Given this list of marker genes Ecrg4, Klhl8, Tdpoz2, Aurka, Traf4, Gid4, Klhl4, Ivns1abp, Nop53, Trip4, Gba1, Klhdc10, Ube2d3, E330034G19Rik, Fbxl18, Itch, Cul2, Afg2b, Psmd2, Clu, Araf, Bag5, Klhl3, Pramel32, Gna12, Rnf186, Gsk3b, Pabpn1l, Ube2u, Trim39, Kbtbd2, Pmp22, Anapc13, Rbck1, Psmb3, Gipc1, Ubxn2b (NCBI Gene Id 76194), Chfr, Cop1, Psmb10, Rchy1, Fem1a, Nkd2, Sharpin, Asb9, Fbxl20, Klhl7, Fbxw11, Anapc7, Nemf, Psma7, Csnk1e, Klhl40, Ube2a, Pramel44, Dcaf12 (NCBI Gene Id 99997), Peli1, Pramel43, Clock, Wac, Axin2, Kbtbd8, Epm2a, Anapc5, Oog2, Stub1, Trf, Fbxl7, Trpc4ap, Nhlrc3, Trip12 (NCBI Gene Id 73751), Ubr3, Klhl38, Psmb7, Klhl41, Fbxo3, Trim13, Ufd1 (ubiquitin recognition factor in ER-associated degradation 1), Clec16a, Csnk1d, Kctd5, Sumo1, Pramel28, Rnf126, Klhl42, Ube2srt, Pml, Gclc, Trim45, Pja2, Pabir1, Bag6, Akirin2, Tdpoz8, Fbxl5, Klhl29, Cul1, Psmd1, Spsb1, Tbx21, Psmc5, Fbxo44, Ube2h, Znrf1, Kbtbd6, Fbxl14, Cbfa2t3, Styx, Csnk2b, Psmc1, Klhl12, Kctd13, Naglu, Cdc20b, Klhl23, Psma5, Armc8, Ube3d, Prickle1, Plk2, Ambra1, Pramel21, Ubxn11, Fbxl6, Smurf2 (SMAD specific E3 ubiquitin protein ligase 2), Zyg11b, Pramel11, Fbxw4, Pramel53, Fbxo4, Fem1al, Anapc2, Pramel51, Pramel42, Tdpoz3, Skp1, Derl1, Psmb4, Psmb9, Kat5, Ankrd9, Zswim8, Ube2n, Spsb2, Fbxl3, Pramel19, Fbxl22, Pramel45, Bbs7, Fbxl2, Pramel60, Trib1, Ubr4, Nploc4, Psmc4, Csnk2a2, Klhl6, Spop, Psmb8, Ubxn7, Trib3, Pramel40, Vhl, Fbxl13, Tnfaip1, Socs2, Kcmf1, Hspbp1, Sh3rf3, Dmac2, Keap1, Asb11, Wdr26, Snhg15, Sh3bgrl, Klhl35, Siah2, Ube2g1, Asb2, Phf20l1, Rad23b, Psmd7, Psmc6, Rbx1, Nedd4l, Plaa, Ubr1, Dtx4, Nub1, Fbxw8, Tdpoz5, Sh3rf1, Mapk8, Ascc2, Klhl11, Psmd8, Pramel13, Rnf216, Klhl24, Fem1b, Trim9, Ubxn1, Huwe1, Marchf6 (membrane associated ring-CH-type finger 6), Psmd10, Ddit3, Ltn1, Zfp418, Fbxw7, Psen1, Fzr1, Fbxo17, Fbxo39, Psmd4, Pramel7, Ccnf, Klhl20, Pramel20, Arih2, Asb1, Fbxw5, Mta1, Anapc4 (NCBI Gene Id 67924), Klhl22, Hectd3, Dcaf11, Gid8, Ube2c, Shh, Ppp2cb, Znrf4, Foxf2, Klhl21, Kbtbd7, Ipp, Psmd14, Tdpoz1, Ube2k, Btrc, Kctd2, Cdc34b, Sirt6, Fbxo9, Pramel46, Usp38, Arrb2, Dab2, Dtl, Psmb11, Pramel37, Gsk3a, Wwp1, Nfe2l2, Pramel18, Pramel36, Rack1, Kctd17, Usp5, Trim72, Cdc27, Pramel35 (PRAME like 35), Plk1 (NCBI Gene Id 18817), Caml, Apc, Spsb3, Ubr5, Rmnd5a, Pcbp2, Psmb5, Klhl15, Psmb2, Pbk, Ercc8, Cul5, Pramel47, Siah1b, Ccin, Tlk2, N4bp1, Pramel48, Cul3, Ube3a, Anapc1, Fbxl19, Rffl, Ubr2 (ubiquitin protein ligase E3 component n-recognin 2), Senp1, Dcaf13, Otud5, Fbxo6, Cdc26, Cul4a, Rbx1-ps, Smurf1 (SMAD specific E3 ubiquitin protein ligase 1), Bmal1, Akt1, Psmf1, Psma8, Nhlrc1, Pramel23, Uchl5, Pramel14, Fbxl4, Herc2, Pramel17, Usp7, Gabarap, Eif3h, Skp2, Wnt10b, Psmc2, Cd2ap, Pramel22, Pramel12, Pias1, Syvn1, Kctd10, Anapc15-ps, Ubxn2a, Ube2d1, Psma2, Taf9, Dvl1, Commd1, Socs4, Klhl28 (NCBI Gene Id 76837), Maea, Pramel25, Bfar, Klhl18, Ascc3, Amn1, Pcnp, Pramel55, Dda1, Psmd6, Rybp-ps, Klhl30, Oog3, Rmnd5b, Tdpoz4, Zfand2a, Ctnnb1, Pramel31, Klhdc1, Styx-ps, Hamp, Trim3, Hspa1a, Pramel41, Rnf180, Psma6, Det1, Smarcc1, Ubqln4, Vcp, Ube2w, Fbxo31, Oog1, Psma1, Paqr3, Rnf170, Fbxo48, Anapc11, Atg7, Klhdc3, Psen2, Zfand2b, Pramex1, Trim71, Ube4b, Appbp2, Pramel33, Nsfl1c, Trim38, Mapk9, Gan, Mtm1, Ube2b, Ufl1, Klhl10, Faf2, Pramel38 (NCBI Gene Id 621019), Ttc36, Fbxo27, Pramel1, Trim26, Trim2, Fhit, Oog4, Klhl5, Anapc16, Hspa1b (heat shock protein 1B), Psma4, Atxn3, Hectd1, Usp9x, Cdc20, Fem1c, Kbtbd3, Fbxo2, Hfe, Siah3, Rybp, Agap3, Psmb6 (proteasome (prosome, macropain) subunit, beta type 6), Sumo2, Ube2s, Ddb1, Psma3 (NCBI Gene Id 19167), Pramel5, Klhl1, Bag2 (BCL2-associated athanogene 2), Pramel15, Ccar2, Tdpoz9, Rnf7, Zfp598, Klhdc2, Trim28 (tripartite motif-containing 28), Desi1, Znrf2, Ddrgk1, Pramel16, Spopl, Rhobtb3, Pramel24, Spsb4, Zer1, Fbxl16, Hsp90ab1, Edem3 (NCBI Gene Id 66967), Usp14, Fbxo7, Fbxl17, Rpl11, Fbxo38, Topors, Ogt, Crbn, Cdc23, Dnajb2 (NCBI Gene Id 76593), Plk3, Arrb1, Tbl1xr1, Ube2v2, Lrrk2, Sirt2, Fbxo22, Socs5, Psmc3, Anapc15, Lrrc75a, Fbxl15, Axin1, Kif14 (NCBI Gene Id 52269), Tbl1x, Apc2, Glmn, Fbxl9, Pramel30, Il33, Gm13040, Nccrp1, Anapc10, Klhl2, Pramel6, Siah1a, Rnf10, Socs7, Rnf187, Sirt1, Kbtbd12, Park7, Ppp2r5c, Pramel29, Trim63, Spopfm3, Map1a, Klhl17 (kelch-like 17), Birc2, Fbxo45, Wwp2 (NCBI Gene Id 66894), Usp26, Csnk1a1, Rad23a, Cdc16, Sh3rf2, Rnf139, Wwtr1, Prkn, Dcaf1, Rnf4, Pramel26, Xpo1, Fbxo11, Spopfm2, Pramel27, Rnf145, Trib2 (tribbles pseudokinase 2), Rnf34, Mdm2, Cdc34, Rnf122, Usp44, here is a description of the gene set: species: Mus musculus The chemical reactions and pathways resulting in the breakdown of a protein or peptide by hydrolysis of its peptide bonds, initiated by the covalent attachment of ubiquitin, and mediated by the proteasome. Mouse Gene Set: GOBP_PROTEASOME_MEDIATED_UBIQUITIN_DEPENDENT_PROTEIN_CATABOLIC_PROCESS